The following is a description of a gene set: species: Homo sapiens Budd-Chiari syndrome Budd-Chiari syndrome (BCS) is caused by obstruction of hepatic venous outflow at any level from the small hepatic veins to the junction of the inferior vena cava (IVC) with the right atrium, 1 and occurs in 1/100,000 of the general population worldwide. The most common presentation is with ascites, but can range from fulminant hepatic failure (FHF) to asymptomatic forms. Obstruction of hepatic venous outflow is mainly caused by primary intravascular thrombosis, which can occur suddenly or be repeated over time, accompanied by some revascularization, accounting for the variable parenchymal hepatic damage and histologic presentation. Budd-Chiari syndrome is thus a disease, but since it occurs as a manifestation of several other diseases, this term is kept for the present for convenience. Human Gene Set: HP_BUDD_CHIARI_SYNDROME, and this is the list of marker genes: TERC, CD55, TERT, JAK2, TINF2, PIGA, F5